Given this list of marker genes Tas2r120, Tas2r134, Lpo, Tas2r123, Car6, Gnat1, Tas2r109, Tas2r104, Tas2r138, Plcb2, Rtp1, Tas2r105, Tas2r108, Tas2r103, Tas2r137, Rtp3, Tas2r107, Tas2r126, Tas2r129, Tas2r131, Tas2r143, Rtp4, Tas2r114, Tas1r2, Tas2r140, Tas2r136, Tas2r124, Tas2r144, Ffar4, Tas2r125, Pip, Tas2r113, Tas2r135, Tas2r119, Tas2r118, Pkd2l1, Rtp2, Pkd1l3, Tas2r116, Gnat2, Tas2r122, Azgp1, Pigr, Tas2r130, Tas2r115, Tas2r117, Tas2r121, Tas1r3, Tas2r110, Tas2r102, Tas2r139, Tas2r106, here is a description of the gene set: The series of events involved in the perception of taste in which a gustatory chemical stimulus is received and converted into a molecular signal. species: Mus musculus Mouse Gene Set: GOBP_DETECTION_OF_CHEMICAL_STIMULUS_INVOLVED_IN_SENSORY_PERCEPTION_OF_TASTE